Given this list of marker genes ZC2HC1A, TAFA3, NUDT1, MTTP, JPT2 (NCBI Gene Id 90861), SLC4A8, DSTN, ARHGAP11A, FDX1, SLC7A3, HIC1, IGSF10, AACS, HMGCL, PACSIN2, KRTCAP2, CDCA4, HMGCR, PSMD6, CEP76, DMWD, TMCC2, RELL1, REEP5, CENPQ, SNUPN, AIMP1, BAG3, NUP43, HAVCR2, HYOU1, ATP5PB, AGA, MRPS18A, SLC1A2, SH2D1A, CAPRIN1, HAUS7, ENKUR, CPT1C, LARS1, PPP2R2D, REEP2, HAUS6, SIRT2, UBA3, PDE4A, PRPF4, GBP6, SEMA4F, RAD50, C1QTNF6, MARS1, CCNG1, ESPN, SF3A3, CCDC60, TNP1, STIM2, CCT8, ADRA1A, CD200, GEM (NCBI Gene Id 2669), NUDCD1, CCDC25, LXN, GNG10, SEPHS2, RAB27A, DDX28, HNRNPA0, KDM8, MRPL51, HSPB6, TMCO4 (NCBI Gene Id 255104), HMGCS1, SLC7A6, METAP2, HYLS1, PSMG2, HOOK1, CDC7, EXOSC3, UBE2F, TMEM14C, SOWAHC, GPX7, FHL3, CCNC, TKFC, EIF4E, TXN, PARP1, APLP2, GEMIN2 (gem nuclear organelle associated protein 2), MGLL, RAVER1, TMEM101, SPP1, TIMELESS, ECI2, PON2, LMBR1, ST13, TRMT5, XPOT, SNX8, DARS1, NOC4L, MID1IP1, RTKN, ARHGEF16, GGTA1, PGAM1, ACTR3B, SPDEF, MRPL41, ZMAT3, CALY, IMPA1, SOWAHB, RIBC1, MPHOSPH6, PPP2R5D, RTKN2, SART3, TPI1, NEDD1, ENDOD1, NACC1, HMGB1, ASNSD1, ETFA, MGAT4B, STARD10, JAZF1, NUMBL, TMEM165, NAA16, KCNK16, SUN1, ICAM1, PGK1, C1QTNF4, CANX, DIO3, MLF1, GIPR, MRPL36, INSIG1, KYAT3, SLITRK5, PIWIL1, SELENOI, MATN4, H1-6, HS3ST4, MTBP, PPP5C (protein phosphatase 5 catalytic subunit), GLOD4, TRIB1, CLDN3, COPS4, PALS2, UFM1, FBXL18, GSR, MYCN, RCC1, XDH, UBE2N, PMPCB, IARS1, DDX19A, here is a description of the gene set: Human monocyte derived dendritic cells matured via galectin-1 or LPS. from publication Fulcher JA, Hashimi ST, Levroney EL, Pang M, Gurney KB, Baum LG, Lee B (PMID 16785517) species: Homo sapiens Genes down-regulated in monocyte-derived dendritic cells: untreated versus vehicle. Human Gene Set: GSE4984_UNTREATED_VS_VEHICLE_CTRL_TREATED_DC_DN